Given this list of marker genes Basp1, Nfkb1, Apex1, Flnb, Mtss1, Bcl2a1b, Uap1l1, Mllt6, Tgfbi, Psmb10, Litaf, G3bp1, Nme1, Spint1, Ssr2, Ccl17, Denr, Mif (NCBI Gene Id 17319), Csf2rb, Eif2s1, Pomp, Aimp2 (aminoacyl tRNA synthetase complex-interacting multifunctional protein 2), Cish, Ube2s, Rrp15, Ccnd2, Napsa (napsin A aspartic peptidase), Rbx1, Map4k1, Txndc17, Kmo, Ifi35, Psma3, Foxn3, Ccnd3, Ndufab1, Nop56, Gspt1, Ccdc86, Rap2a, Bccip, Tapbpl, F2rl2, Ifitm2, Tspo, Stub1, Snrpa1, Orai1, Ftl1, Tes, Ostc, Slc25a5 (solute carrier family 25 (mitochondrial carrier, adenine nucleotide translocator), member 5), Nip7, Psmb6, Clic4, Nhp2, Chd7, Atp5f1b, Cst3, Ifitm3, H2-DMb2, Adam19, Psmd12, Rwdd1, Cox5a, Swi5, Bcl7c, Fabp5, Bcl2a1a, Psmb5, Psme2, Pip4k2a, Pgk1, Tsg101, Ebna1bp2, Cdk2ap2, Sdad1, Smdt1, Srsf2, Gnb4, Efhd2, Pacsin2, Ciita, Prelid1, Dusp2, Rbm3, Eno1, Ppa1, Mbd2, Arpc1b, Cyria, Eif4a1, Srsf7, Prkcd, Eif5a, Twf2, Fcer1g, Cnbp, Myl12a, Sf3b6 (NCBI Gene Id 77722), Ruvbl1, Itgae, Mrps28, Ost4, Spi1, Psmb8, S100a6, Sri, Irf5, Slfn2, Macroh2a1, Tuba1a (tubulin, alpha 1A), Serpina3g, Exosc3 (NCBI Gene Id 66362), Naaa, Rras2, Cops5, Coro2a, Gpsm3, Serp1, Ldha, Cct3, Tagln2, Casp8 (NCBI Gene Id 12370), Lcp1, Fh1, Tor1a, Pgd, Mrto4, Exosc7, Pfkp, Mrpl20, Plgrkt, Rars1, Trio (NCBI Gene Id 77730), Ctsz, Gnl3, Rexo2, Eif1ax, Cacybp, Ppp1r14b, Slc8b1, Pfn1, Snrpd1, Cdkn1a, Ranbp1, Prdx1, Slc35b1, Anxa2, Psmb7, Eny2, Psma7, Calm1, Lims1, Psmd2, Lgals3, Csrp1, Psma4, Snx3, Mtmr4, Pdia6, Socs2, Cbfa2t3, Cd300a, Wfdc17, Pnp, Mkrn1, Larp1b, Rara, Tuba1b, Mybbp1a, Srsf9, Fth1, Ptcd2, Cstb, S100a13, Psmb3, Smarce1, Lgals1, Akt1, Atp5mc1, Vasp (vasodilator-stimulated phosphoprotein), Ptpn1, Prmt1 (protein arginine N-methyltransferase 1), E2f5, Pfdn6, Bcl2a1d, Tcp1, Ran, Srgn, Nop58, Odc1, here is a description of the gene set: Mouse Gene Set: CUI_CDC1_IL3_RESPONSE_UP studied in species Mus musculus Cytokines mediate cell-cell communication in the immune system and represent important therapeutic targets. A myriad of studies have highlighted their central role in immune function, yet we lack a global view of the cellular responses of each immune cell type to each cytokine. To address this gap, the authors created the Immune Dictionary, a compendium of single-cell transcriptomic profiles of more than 17 immune cell types in response to each of 86 cytokines (>1,400 cytokine-cell type combinations) in mouse lymph nodes in vivo. A cytokine-centric view of the dictionary revealed that most cytokines induce highly cell-type-specific responses. For example, the inflammatory cytokine interleukin-1β induces distinct gene programmes in almost every cell type. A cell-type-centric view of the dictionary identified more than 66 cytokine-driven cellular polarization states across immune cell types, including previously uncharacterized states such as an interleukin-18-induced polyfunctional natural killer cell state. from publication Cui A, Huang T, Li S, Ma A, Pérez JL, Sander C, Keskin DB, Wu CJ, Fraenkel E, Hacohen N (PMID 38057668) Genes positively differentially expressed in cell type: cDC1 (conventional dendritic cell type 1) upon treatment with cytokine: IL-3 in mouse lymph nodes in vivo.